Given this list of marker genes Csnk1e, Tuba1a, Dynll1, Cep152, Tubb4a, Clasp1, Cep192, Tubb4b, Prkaca, Haus7, Dctn1, Nde1, Cep135, Ywhae, Cep72 (centrosomal protein 72), Cep290, Plk1, Sdccag8, Haus1, Cenpj, Cep43, Actr1a (NCBI Gene Id 54130), Sfi1, Nedd1, Tpx2, Cep131, Tuba4a, Haus5, Cdk1, Haus8, Prkar2b, Cep57, Ninl, Cep41, Cep63, Hmmr, here is a description of the gene set: Reactome Pathway: AURKA Activation by TPX2 part of: G2/M Transition This event has been computationally inferred from an event that has been demonstrated in another species.<p>The inference is based on the homology mapping from PANTHER. Briefly, reactions for which all involved PhysicalEntities (in input, output and catalyst) have a mapped orthologue/paralogue (for complexes at least 75% of components must have a mapping) are inferred to the other species. studied in species Mus musculus electronically inferred by orthology from the curated human pathway